Given this list of marker genes PHF2, RLF, MACROH2A1, CDK2, TPR, PHF8, DNMT3L, BAZ1A, KMT2A, DYRK1A, here is a description of the gene set: Any process that modulates the frequency, rate, extent or location of heterochromatin formation. Human Gene Set: GOBP_REGULATION_OF_HETEROCHROMATIN_FORMATION species: Homo sapiens